Given this list of marker genes SF3B2, PPM1G, HADHA, PTGES3, VDAC2, SNRPA1, H2AZ1, NSDHL, RFC2, HCCS, DDX1, NUP205, SRSF9, SDHB, LMNB2 (lamin B2), PTPN11, PARK7, HSPA9, TUFM, LSM4, VBP1, TRIM28, SCAMP3, EIF3C, DARS1, NDUFV2 (NCBI Gene Id 4729), TOMM70, NDUFV1, AARS1 (NCBI Gene Id 16), RAD23A, ATP5PO, NDUFS3, CSNK2B, CHERP, MTDH, SMC3, CCT8, SNRPA, ERP29, BUB3, CDK4, UQCRC1, VDAC1, ATP5MC3, SF3A1, CYCS, IRAK1, GMPS, VAMP7, PCLAF, HDDC2, NDUFS8, ACOT13, here is a description of the gene set: Neighborhood of GMPS studied in species Homo sapiens Neighborhood of GMPS guanine monphosphate synthetase in the MORF expression compendium Human Gene Set: MORF_GMPS